Given this list of marker genes RREB1, PASK, WASF3, P2RY12, CDC37L1, SLC4A8 (solute carrier family 4 member 8), ZNF518A, TRIM66, SELENON, ZNRF1, HSPD1, LRP8, TAS2R14, XKR5, CDKN1B, MIS12, ZNF552, OR11A1, PSMD1, NETO1, ESYT1 (extended synaptotagmin 1), PHAF1, CREBBP, ZFAND1, RPL7L1, GPATCH2, TBL1XR1, SPATA17, KDM5A, MDM4, PROSER1, GOLGB1, KIF3B, GABPB1, ALG11, ZNF704, CACNB4, EHD4, THRB, KLF7, PLCL1, TDRD6, HOXA10, TRAK1, GINS4, PPM1F, DDX4, TAF12, CNOT7, NCKAP5, SMKR1, LRRC15, AGAP1, NOVA1, CCL14, TCERG1, KLF3, SLC4A10, HACD4, CHUK, ZBTB18, PHF21A, CUL4B, RAD1, ZFP1, BEST4 (NCBI Gene Id 266675), ZNF559-ZNF177, SLC17A2 (NCBI Gene Id 10246), ZNF618, GALNT15, TNS1, LINC01517, EEA1, BMPR1A, MTFR1L, SGPL1, NECAB1, ERC1, LSAMP, HPRT1, RAD54B, PAK2, C1orf56, UBALD1, SH3TC2, NRXN1, TPH1, GALNT2, EDA2R, TMEM132B, MEX3A, CD83, GJC1, SYN1, B3GALNT1, TMEM178B, SLC7A1, SLC30A6, PIGP, ZNF302, PLTP, CFAP97, LAMC1, ESR1, MAPRE2, PIAS1, USP49, EXOC6, PLAUR, CHCHD7 (NCBI Gene Id 79145), HEPACAM, MTMR1, DIAPH2, CCDC32 (NCBI Gene Id 90416), ZNF620, WDHD1 (NCBI Gene Id 11169), SLC49A4, SUPT16H (NCBI Gene Id 6831), SC5D, ZNF75D, COX11, WWP2, DEPDC4, SMIM8, DDX6, RBM15, PDK1, SPRING1, PHACTR3, C22orf46P (NCBI Gene Id 79640), ADGRF5, GPC6, DCT, SNX10 (NCBI Gene Id 29887), VGLL3, PLPPR1, ZMYND8, ZNF135, ANKRD34B, UBIAD1, PKP2, PACRG (parkin coregulated), B4GALT6, GUCA1C (NCBI Gene Id 9626), RHOBTB3, LPP, NEDD9, SLC66A1LP, ZNF276, KIAA1549L, CACNA1E, SMPDL3B, NAB1 (NGFI-A binding protein 1), GDNF (NCBI Gene Id 2668), TAT (tyrosine aminotransferase), CYP2U1, LMNA, CHST2, BCO1, GPR85, SGMS1, KCNB1, TNIK, CHCHD3, EMP2, FXR1, RND3, XRN1, RALBP1, CALHM1, DAG1, CREBRF, CIPC, MAT2A, SENP7, PIF1, DCDC1, GNAL (NCBI Gene Id 2774), CNTD1, CLVS2, OPCML (opioid binding protein/cell adhesion molecule like), DUSP16, C8A, USP27X, CCBE1, KNG1, PFKFB2, CHEK1, RANBP3L, PRKG1, BHLHE40, AFG1L, DCAF4L2, PLXNA4, RBM20, TAOK1, PLEKHM3, TGFA, NAA50, DMAC1, NOTCH2, YAF2, MRPL33, ARPC5L, AVL9, API5, PCDHB12, SURF6, LEP, FUT8, RAB3B, STIMATE, MECP2, ATXN7, ARSB, here is a description of the gene set: Human Gene Set: MIR942_5P Genes predicted to be targets of miRBase v22 microRNA hsa-miR-942-5p in miRDB v6.0 with MirTarget v4 prediction scores > 80 (high confidence targets). from publication Chen Y, Wang X (PMID 31504780) studied in species Homo sapiens